The following is a description of a gene set: The multiplication or reproduction of cells, resulting in the expansion of a mesenchymal cell population that contributes to the progression of the lung over time. A mesenchymal cell is a cell that normally gives rise to other cells that are organized as three-dimensional masses, rather than sheets. studied in species Homo sapiens Human Gene Set: GOBP_MESENCHYMAL_CELL_PROLIFERATION_INVOLVED_IN_LUNG_DEVELOPMENT, and this is the list of marker genes: FGFR2, PHF14, SHH (sonic hedgehog signaling molecule), NFIB, TBX2 (NCBI Gene Id 6909, T-box transcription factor 2), CTNNB1